Given this list of marker genes NRAS, LYN, JAK2, SOS1, SHC1, KRAS, PIK3R1, STAT5B (signal transducer and activator of transcription 5B), IRS2, EPO, PLCG2, PIK3CA, EPOR, PIK3CD, PLCG1, CRKL, STAT5A, GAB1, HRAS, PIK3CG, VAV1 (vav guanine nucleotide exchange factor 1), RAPGEF1, GRB2, PIK3R5, PIK3CB, here is a description of the gene set: Reactome Pathway: Signaling by Erythropoietin part of: Signal Transduction studied in species Homo sapiens Erythropoietin (EPO) is a cytokine that serves as the primary regulator of erythropoiesis, the differentiation of erythrocytes from stem cells in the liver of the fetus and the bone marrow of adult mammals. EPO is produced in the kidneys in response to low oxygen tension and binds a receptor, EPOR, located on progenitor cells: burst forming unit-erythroid (BFU-e) cells and colony forming unit-erythroid (CFU-e) cells.<br>The erythropoietin receptor (EPOR) exists in lipid rafts as a dimer pre-associated with proteins involved in downstream signaling: the tyrosine kinase JAK2, the tyrosine kinase LYN, and the scaffold protein IRS2. Binding of EPO to the EPOR dimer causes a change in conformation that activates JAK2, which then transphosphorylates JAK2 and phosphorylates the cytoplasmic domain of EPOR. The phosphorylated EPOR serves directly or indirectly as a docking site for signaling molecules such as STAT5, phosphatidylinositol 4,5-bisphosphate 3-kinase (PI3K), phospholipase C gamma (PLCG1, PLCG2), and activators of RAS (SHC1, GRB2:SOS1, GRB2:VAV1).<br>EPO activates 4 major signaling pathways: STAT5-activated transcription, PI3K-AKT, RAS-RAF-ERK, and PLC-PKC. JAK2-STAT5 activates expression of BCL2L1 (Bcl-xL) and therefore appears to be important for anti-apoptosis. PI3K-AKT appears to be important for both anti-apoptosis and proliferation. The roles of other signaling pathways are controversial but both RAS-RAF-MEK-ERK and PLCgamma-PKC have mitogenic effects. Phosphatases such as SHP1 are also recruited and downregulate the EPO signal.<br>EPO also has effects outside of erythropoiesis. The EPOR is expressed in various tissues such as endothelium where it can act to stimulate growth and promote cell survival. EPO and EPOR in the neurovascular system act via Akt, Wnt1, mTOR, SIRT1, and FOXO proteins to prevent apoptotic cell injury and EPO may have therapeutic value in the nervous system.